The following is a description of a gene set: studied in species Mus musculus Mouse Gene Set: GOBP_NUCLEOTIDE_SUGAR_TRANSMEMBRANE_TRANSPORT The directed movement of nucleotide-sugars into, out of or within a cell, or between cells, by means of some agent such as a transporter or pore. Nucleotide-sugars are any nucleotide in which the distal phosphoric residue of a nucleoside 5'-diphosphate is in glycosidic linkage with a monosaccharide or monosaccharide derivative., and this is the list of marker genes: Slc35a3, Slc35b1, Tmem241, Slc35a5, Slc35b4, Slc35c2, Slc35a2, Slc35a1, Slc35d1, Slc35c1, Slc35d2, Slc35d3